The following is a description of a gene set: The regulated turnover of glycogen plays a central, tissue-specific role in the maintenance of blood glucose levels and in the provision of glucose to tissues such as muscle and brain in response to stress. Defects in the enzymes involved in glycogen turnover are associated with abnormal responses to fasting and exercise that can differ widely in their presentation and severity. Additional symptoms can be the result of accumulation of abnormal products of glycogen metabolism. Annotations are provided here for diseases due to deficiencies of GYS1 and GYS1 (glycogen synthase 1 and 2; glycogen storage disease type 0 (GSD type 0), of G6PC (glucose-6-phosphatase, GSD type Ia) and the SLC37A4 transporter (GSD type Ib), of GAA (lysosomal acid alpha-glucosidase, GSD type II), of GBE1 (glycogen branching enzyme, GSD type IV), and of GYG1 (glycogenin 1, GSD XV). Two additional diseases, myoclonic epilepsy of Lafora and severe congenital neutropenia type 4, are included as they are due to defects in enzymes of glycogen metabolism. part of: Diseases of carbohydrate metabolism species: Homo sapiens Reactome Pathway: Glycogen storage diseases, and this is the list of marker genes: UBA52, EPM2A, SLC37A4, NHLRC1, PPP1R3C, GYG1, RPS27A, GYS1 (glycogen synthase 1), GAA, GYS2, UBB, G6PC1, GBE1 (NCBI Gene Id 2632), G6PC3, UBC, GYG2